Given this list of marker genes ACSM2A, GLYAT, GLYATL1, GLYATL3, ACSM4 (acyl-CoA synthetase medium chain family member 4), ACSM5, ACSM2B, ACSM1, GLYATL2, here is a description of the gene set: Reactome Pathway: Conjugation of carboxylic acids Xenobiotics and endogenous compounds containing carboxylate groups can be activated with coenzyme A to produce acyl-CoA thioesters and then conjugated with the amino groups of glycine or glutamine to form amide-linked conjugates. Clinically important substrates include benzoic acid, phenylacetic acid, and salicylic acid. part of: Amino Acid conjugation species: Homo sapiens